The following is a description of a gene set: Increased thickness (diameter) of ribs. Thickened ribs Human Gene Set: HP_THICKENED_RIBS species: Homo sapiens, and this is the list of marker genes: HGSNAT, SOST, GLB1, IDS, NAGLU, SGSH, GNS, MAN2B1